The following is a description of a gene set: Reactome Pathway: Loss of Function of SMAD2/3 in Cancer Loss-of-function of SMAD2 and SMAD3 in cancer occurs less frequently than the loss of SMAD4 function and was studied in most detail in colorectal cancer.<br><br>Similarly to SMAD4, coding sequence mutations in SMAD2 and SMAD3 in cancer cluster in the MH2 domain, involved in the formation of transcriptionally active heterotrimers with SMAD4. Another region of SMAD2 and SMAD3 that is frequently mutated in cancer is the phosphorylation motif Ser-Ser-X-Ser at the very C-terminus. The phosphorylation of this conserved motif by the activated TGF-beta receptor complex is an essential step in SMAD2 and SMAD3 activation and a prerequisite for the formation of heterotrimers with SMAD4.<br><br>Smad2 knockout mice die at embryonic day 8.5, with impaired visceral endoderm function and deficiency in mesoderm formation. Smad2+/- heterozygotes appear normal and are fertile. While polyps of compound Smad2+/-;Apc+/- mice show no difference in the number, size or histopathology from the polyps of Apc+/- mice, Smad2+/-;Apc+/- mice develop extremely large intestinal tumors and multiple invasive cancers not observed in Apc+/- mice. Therefore, loss of Smad2 does not contribute to initiation of intestinal tumorigenesis, but accelerates malignant progression. Smad3 knockout mice are viable and fertile but die between 4 and 6 months of age from colorectal adenocarcinoma, indicating that the loss of Smad3 initiates intestinal tumorigenesis. studied in species Homo sapiens part of: Signaling by TGF-beta Receptor Complex in Cancer, and this is the list of marker genes: TGFB1, SMAD3, TGFBR1, ZFYVE9, TGFBR2, SMAD2, SMAD4